Given this list of marker genes ARG2, H3-3A, TMEM186, FOXN4, YKT6, SFSWAP, ANKRD13A, DGKQ, GCAT, SOX15 (SRY-box transcription factor 15), CTBP2, DCXR, NT5E, PPP1R14D, WARS1, C1orf198, AP2M1, ITGB4, SUB1, MSLNL, MRPL35, NME3, PARD6A, ARPP19, LRCH4, FASTK, QARS1, RPP25L, ADAP1, WDR90, ABCB6, KATNIP, RARRES2, TK1 (NCBI Gene Id 7083), SPRYD4, COTL1, DNAJC7, RARS2, BLCAP, CELSR3, DRG2, TGM1, BUB1B, RCCD1, SNAI3, RTL6, RAC3, DND1, GNPTG, ANKMY2, CCDC28B, CUL7, DHODH, CEP15, URAHP, BDH2, AGFG1, ITGA3, ZNF579, CDC20, IL11RA (NCBI Gene Id 3590), TCEA3, NISCH, COX6A2, F2R, GNA11, SGCB, TGM2, CWC22, CORO1A (coronin 1A), FKBP6 (FKBP prolyl isomerase family member 6 (inactive)), GRK6, GFPT2, IFT172, PHYKPL, CPE, DIRAS1, ATP2A3, DDX27, KDM4B, RPS6KA4, EVC, POLDIP2, SPATA24, KDM1A, PTPA, ACOT8, UBE2D3, SDHAF1, UBE3B, IRF2BP1, PLOD1, TMEM131, NDST2, ELAC1, CRIP2, PIAS3, DDX25, EIF3C, UBR7, OTUB2, SLC28A1, TNRC6C, SLC25A44, DUSP11, GNG13, BCAM, GLI2, SHC1, PIK3R2, FUOM, AMPD3, KRBA1, STRIP1, ELMO3, NOS3, ANKZF1, RNF225, NPEPL1, CC2D2A, TET2, PBX2, SCLY, RNMT, TAF5, R3HDM4 (NCBI Gene Id 91300), PLCD1, VRK1, TIA1, KRT7, SAP30, ANKRA2, UBE2E1 (NCBI Gene Id 94682), AP1B1, RDM1, HAGHL, APLP1, GFM2, BCKDHA (branched chain keto acid dehydrogenase E1 subunit alpha), CELF4, TMEM141, RASSF1, ACAD10, VPS45 (NCBI Gene Id 11312), TFDP1, NAT8, GTPBP2 (GTP binding protein 2), ECHS1, FHIP1B, NT5C3B, SCYL1, NAA80 (NCBI Gene Id 24142), FAM110A, INTS11, ZCWPW1, RUVBL2, ETFBKMT, TRMT1L, AKAP9, RARG, PEX11A, RAPGEF3, DDIT3, TBC1D2, LZTR1, IDH3A, TUBGCP2, B4GAT1, BAIAP2, PGLS, TRABD, CPB2, MRPL10, LTBP3, NDUFB11, WIPI2, LRFN3, RBKS, ENO3, MTHFD2, CHKB, BTBD1, CIZ1, POLA2, SNX17, SLC6A9, LRRC40, POU2F1, MZT2B, NADK, SEC14L1, RIOK3, NAPRT, DIS3L, ATP11B, MYD88, CPLX1, TRIOBP, CIART, SNN, DLGAP5 (DLG associated protein 5), METRN, here is a description of the gene set: Human Gene Set: FOSTER_KDM1A_TARGETS_DN Genes down-regulated in ES cells (embryonic stem) heterozygotic for KDM1A loss of function mutant compared to the homozygotic loss of the gene. Lysine-specific demethylase 1 (LSD1), which demethylates mono- and dimethylated histone H3-Lys4 as part of a complex including CoREST and histone deacetylases (HDACs), is essential for embryonic development in the mouse beyond embryonic day 6.5 (e6.5). To determine the role of LSD1 during this early period of embryogenesis, we have generated loss-of-function gene trap mice and conditional knockout embryonic stem (ES) cells. Analysis of postimplantation gene trap embryos revealed that LSD1 expression, and therefore function, is restricted to the epiblast. Conditional deletion of LSD1 in mouse ES cells, the in vitro counterpart of the epiblast, revealed a reduction in CoREST protein and associated HDAC activity, resulting in a global increase in histone H3-Lys56 acetylation, but not H3-Lys4 methylation. Despite this biochemical perturbation, ES cells with LSD1 deleted proliferate normally and retain stem cell characteristics. Loss of LSD1 causes the aberrant expression of genes, including those coding for transcription factors with roles in anterior/posterior patterning and limb development, such as brachyury, Hoxb7, Hoxd8, and retinoic acid receptor γ (RARγ). The gene coding for brachyury, a key regulator of mesodermal differentiation, is a direct target gene of LSD1 and is overexpressed in e6.5 Lsd1 gene trap embryos. Thus, LSD1 regulates the expression and appropriate timing of key developmental regulators, as part of the LSD1/CoREST/HDAC complex, during early embryonic development. from publication Foster CT, Dovey OM, Lezina L, Luo JL, Gant TW, Barlev N, Bradley A, Cowley SM (PMID 20713442) species: Mus musculus